The following is a description of a gene set: Mouse Gene Set: MIR_3060_3P studied in species Mus musculus from publication Chen Y, Wang X (PMID 31504780) Genes predicted to be targets of miRBase v22 microRNA mmu_miR_3060_3p in miRDB v6.0 with MirTarget v4 prediction scores > 80 (high confidence targets)., and this is the list of marker genes: Rhou, Tnfrsf22, Slc25a46, Spop, Aacs, Ammecr1, Tgfbi, Eif4g2, Zfp518a, Ids, Gja6, Ccnj, Tigd2, Itgb3, Zfp503, Prl5a1, Orc1, Socs6, Tmem161a, Cdk19, Tubal3, Dennd6a, Rasa1, Robo2, Polb, Thra, Egf, Rfx5, Fam186a, Usp6nl, Serpind1 (NCBI Gene Id 15160), Trim9, Cdk5r1, Clcn4, Epb41l5, Cyp2j13, Rb1, Gmpr, Nap1l5, Nefl, Mdfic, Spock1, Kif21a, Kif3a, Fam167a, Cxcl14, Tmem229a, Rala, Jmjd1c, Cyfip2, Mrpl41, Rnf152, Fam13a, Ak4, Otud4, Tbc1d10b (NCBI Gene Id 97416), Htr3a, Ccng1, Nol4, Hycc2, Zfp950, Nfyc, Med21, Golga4 (NCBI Gene Id 54214), Sptbn1, Bod1l, Zbtb41, Dpy19l1, Mdm4, Nalcn, Zfp655, Gm5134 (NCBI Gene Id 333669), Bptf, Tsga10, Tead1 (TEA domain family member 1)